Given this list of marker genes KMT2A, HMGA2, NLRC3, PEX2, S100A6, B4GALT7, RNASEH2B, TGFB1, HTN3, IFI30 (IFI30 lysosomal thiol reductase), MYC, NGFR, DDR2, WNT5A, GAS6, INCA1, GSTP1, WNT2, SKI, FOSL2, PLA2G1B, LZTS2, CDK4, TRIM32, ING5, MIF, AQP1, FN1, EMD, LTA, WNT1, PARP10, CD248, MYB, ABL1, SFRP1, TP53INP1, ZMPSTE24, CDC73, IL13, JUN, TGIF1, AGT, SIRT6, FBLN1, PML, MIR17, HRAS, MED25, CDC6, CTNNB1, FTH1, DHX9 (DExH-box helicase 9), PAWR, PDGFD, FGF10, LIG4, DAB2IP, LIF, NUPR1, FBXO4, ZMIZ1, IGF1, DACH1, C1QL4, CTC1, MED31, MORC3, PDGFB, CCNB1, BAX, ESR1 (estrogen receptor 1), PDGFC, EREG, CREB1, BMI1, CD74 (NCBI Gene Id 972), CDKN1A (NCBI Gene Id 1026), CDK6, PDGFA, SOD2, CD300A, E2F1, TP53, BRK1, CAV1, NF1, PDGFRA, MIR494, SPHK1, EGFR, ITGB3, BTC, CCNA2, here is a description of the gene set: Any process that modulates the frequency, rate or extent of multiplication or reproduction of fibroblast cells. Human Gene Set: GOBP_REGULATION_OF_FIBROBLAST_PROLIFERATION species: Homo sapiens